Given this list of marker genes TBX5, ZFPM1, ACVR1 (activin A receptor type 1), SMAD4, SLIT3, DCHS1, EFNA1, TGFBR2, HEY1, HEY2, NOTCH1, HEYL, BMPR2, PITX2 (paired like homeodomain 2), GATA4, ADAMTS19 (NCBI Gene Id 171019), NAGLU, SMAD6 (NCBI Gene Id 4091), TBX20, MDM4, AXIN2 (axin 2), MDM2, APLNR, CCN1, TWIST1, BMP2, TGFB2, OLFM1, GJA5, BMPR1A, SOX4, here is a description of the gene set: Human Gene Set: GOBP_ATRIOVENTRICULAR_VALVE_DEVELOPMENT species: Homo sapiens The progression of the atrioventricular valve over time, from its formation to the mature structure.